The following is a description of a gene set: species: Mus musculus Any process that modulates the frequency, rate or extent of the directed movement of proteins from the nucleus to the cytoplasm. Mouse Gene Set: GOBP_REGULATION_OF_PROTEIN_EXPORT_FROM_NUCLEUS, and this is the list of marker genes: Ywhae, Camk4, Uhmk1, Cdkn2a, Frat2, Rbm22, Cdk5, Prpf4b, Park7, Gsk3b, Chchd4, Mdm2, Sirt6, Sp100, Peg12, Rangap1, Bard1, Anp32b, Tpr, Prkaca, Bag3, Ctdspl2, Txn1, Ppm1a, Ptpn11, Hdac3, Xpo1, Rapgef3, Wipf1, Gas6, Ifi27, Xpo4, Sfn, Prkd1, Frat1, Ptpn14, Fam76b, Emd, Sirt7, Camk1